Given this list of marker genes Foxl2 (NCBI Gene Id 26927), Inhba, Smad4, Lep, Ucn2, Inhbb, Inha, Crhr2 (NCBI Gene Id 12922, corticotropin releasing hormone receptor 2), Acvr2a, here is a description of the gene set: Mouse Gene Set: GOBP_REGULATION_OF_FOLLICLE_STIMULATING_HORMONE_SECRETION species: Mus musculus Any process that modulates the frequency, rate or extent of the regulated release of follicle-stimulating hormone.